Given this list of marker genes Ly96, Lbp, Arf6, Dab2ip, Scimp, Prkce, Tax1bp1, Ninj1, Tbk1, Tmem126a, Ifi35, Letmd1, Mfhas1, Naglu, Appl2, F2rl1, Lyn, Ripk2, Nmi, Oas1d, Rab11fip2, Tirap, Irf3, Oas1h, Bpifb1, Ticam2, Oas1c, S100a14, Traf3, Oas1b, Irak2, Ticam1, Ecsit, Myd88, Tnip3, Nr1h3, Rela, Trem2, Trim32, Peli1, Oas1g, Map3k7, Znrf1, Acod1, Oas1f, Cd14, Wdfy1, Sqstm1, Ptpn22, Nr1d1 (NCBI Gene Id 97769), Lrrfip2, Oas1a, Appl1, Irak1, Pik3ap1, Traf6, Ltf, Pik3r1, Tlr4, Hmgb1, Rab7b, Nfkbia, Tril (NCBI Gene Id 66873), Chuk, Oas1e, here is a description of the gene set: Mouse Gene Set: GOBP_TOLL_LIKE_RECEPTOR_4_SIGNALING_PATHWAY The series of molecular signals initiated by a ligand binding to toll-like receptor 4. studied in species Mus musculus